Given this list of marker genes PRKG2, TBX5, ALMS1, CHRNA1, RAB5IF, NKX3-2, DES (NCBI Gene Id 497658), MUSK, PUF60, DOK7, MYPN, ACTA1, BAG3, PEX5, VPS13B, COG1, RAB3GAP2, MYH7, KMT2D, COL13A1, PIK3R2, PLK4, RBBP8, CHRND, SOX9, WDR81, CHRNB1, LRP4, SPRTN, EXTL3, ERLIN1, SERPINH1, TPM2, AK9, AEBP1, SOX5, ZFX, GDF3, NEK9, PCGF2, ITCH (itchy E3 ubiquitin protein ligase), DMD, PYCR2, IARS2, ZMPSTE24, GNS, TPM3, RAPSN, KDM6A, SCN4A, HINT1, AGRN, MTRFR, NFIX, TUBB3, MOGS, LMNA, SGCA (sarcoglycan alpha), CHRNE, PLOD1, ADGRG6, here is a description of the gene set: studied in species Homo sapiens Human Gene Set: HP_THORACIC_SCOLIOSIS Thoracic scoliosis